Given this list of marker genes TALDO1, PACSIN1, GSTA4, ANKRD1, BNIP3, NQO1, CPSF6, ALDH2, SNX10, KLF7, PTPMT1, AKR7A2, CCNA1, KLF5, APOE, HAGH, CPEB1, CCNE2, BLOC1S5, GSTT2, SCARA3, APLP1, HMOX1, GSTK1, ENSG00000308298, MGST3, RAC3, PRDX1, PARN (poly(A)-specific ribonuclease), NUDT21, CAT, KLF12, EID3, DDX17, PTBP2, AKR1C3, KLF10, IDH2, AKR1A1, SHANK3 (NCBI Gene Id 85358), TXNDC11, RBM25, ALDH1A3, PACSIN3, NDUFS1, AGO2, CPEB3, PCF11, here is a description of the gene set: from publication Mellman DL, Gonzales ML, Song C, Barlow CA, Wang P, Kendziorski C, Anderson RA (PMID 18288197) Genes down-regulated in HEK293 cells (embryo kidney) after knockdown of TUT1 by RNAi. Human Gene Set: MELLMAN_TUT1_TARGETS_DN Phosphoinositides are a family of lipid signalling molecules that regulate many cellular functions in eukaryotes. Phosphatidylinositol-4,5-bisphosphate (PtdIns4,5P2), the central component in the phosphoinositide signalling circuitry, is generated primarily by type I phosphatidylinositol 4-phosphate 5-kinases (PIPKIalpha, PIPKIbeta and PIPKIgamma). In addition to functions in the cytosol, phosphoinositides are present in the nucleus, where they modulate several functions; however, the mechanism by which they directly regulate nuclear functions remains unknown. PIPKIs regulate cellular functions through interactions with protein partners, often PtdIns4,5P2 effectors, that target PIPKIs to discrete subcellular compartments, resulting in the spatial and temporal generation of PtdIns4,5P2 required for the regulation of specific signalling pathways. Therefore, to determine roles for nuclear PtdIns4,5P2 we set out to identify proteins that interacted with the nuclear PIPK, PIPKIalpha. Here we show that PIPKIalpha co-localizes at nuclear speckles and interacts with a newly identified non-canonical poly(A) polymerase, which we have termed Star-PAP (nuclear speckle targeted PIPKIalpha regulated-poly(A) polymerase) and that the activity of Star-PAP can be specifically regulated by PtdIns4,5P2. Star-PAP and PIPKIalpha function together in a complex to control the expression of select mRNAs, including the transcript encoding the key cytoprotective enzyme haem oxygenase-1 (refs 8, 9) and other oxidative stress response genes by regulating the 3'-end formation of their mRNAs. Taken together, the data demonstrate a model by which phosphoinositide signalling works in tandem with complement pathways to regulate the activity of Star-PAP and the subsequent biosynthesis of its target mRNA. The results reveal a mechanism for the integration of nuclear phosphoinositide signals and a method for regulating gene expression. species: Homo sapiens